Given this list of marker genes Stfa3, Mmp12, Tnfaip2, Ctsb, Slc11a1, Cxcl2, Mafb, Clec4e, Igsf6, Acp5, Myo5a, Cd68, Ngp, C1qc, Adgre4, Saa3, Ms4a7, Slfn1, Slc15a3, Fcgr3, Ly9, Aar2, Lilrb4b, Dnmt3a, Slc40a1, C1qa (complement component 1, q subcomponent, alpha polypeptide), Mpeg1, Msr1, Clec4n, Mmp19, Stfa1, Trem2, Rgs1, C1qb, Neu1, Ms4a6c, Klrb1b, Camp, Spic, Apobec1, Snx6, Pira1, Fcna, Hmox1, Atp6v0d2 (NCBI Gene Id 77165), Cfp, Slfn4, Cd244a, Mmp8, Tlr7, Pla2g7, Gdf15, Ms4a6d, Xist, C3ar1, Ccr1, Marco, Fkbp5, Clec4d, Cd5l, Utrn, Fcgr2b, Acod1, S100a9, Steap4, Sema7a, Fabp7, Fcer1g, Gpnmb, Il1r2, here is a description of the gene set: studied in species Mus musculus Genes up-regulated at 3 months of age in lungs from LIPA knockout mice, which display pulmonary pathology. from publication Lian X, Yan C, Qin Y, Knox L, Li T, Du H (PMID 16127159) The functional roles of neutral lipids in the lung are poorly understood. However, blocking cholesteryl ester and triglyceride metabolism in lysosomal acid lipase gene knockout mice (lal-/-) results in severe pathogenic phenotypes in the lung, including massive neutrophil infiltration, foamy macrophage accumulation, unwanted cell growth, and emphysema. To elucidate the mechanism underlining these pathologies, we performed Affymetrix GeneChip microarray analysis of 1-, 3-, and 6-month-old mice and identified aberrant gene expression that progressed with age. Among changed genes, matrix metalloproteinase (MMP)-12, apoptosis inhibitor 6 (Api-6), erythroblast transformation-specific domain (Ets) transcription factor family member Spi-C, and oncogene MafB were increased 100-, 70-, 40-, and 10-fold, respectively, in lal-/- lungs versus the wild-type lungs. The pathogenic increases of these molecules occurred primarily in alveolar type II epithelial cells. Transcriptional activities of the MMP-12 and Api-6 promoters were stimulated by Spi-C or MafB in respiratory epithelial cells. Treatment with 9-hydroxyoctadecanoic acids and ciglitazone significantly rescued lal-/- pulmonary inflammation and aberrant gene expression. In addition, both compounds as well as peroxisome proliferator-activated receptor gamma inhibited MMP-12 and Api-6 promoter activities. These data suggest that inflammation-triggered cell growth and emphysema during lysosomal acid lipase deficiency are partially caused by peroxisome proliferator-activated receptor-gamma inactivation. Mouse Gene Set: LIAN_LIPA_TARGETS_3M